The following is a description of a gene set: Methylation Mouse Gene Set: REACTOME_METHYLATION studied in species Mus musculus, and this is the list of marker genes: Gsto1, Comt, Nnmt, Tpmt, As3mt, Trmt112, Mtrr, Mat2b, N6amt1, Mat1a, Ahcy, Ahcyl, Mtr, Mat2a, Cyp1a2